Given this list of marker genes PTPN1 (NCBI Gene Id 5770), POP1, CSDE1, ACSL1, RAD23B, UCK2, RPS6KB1, FXR1, DNMT3B, FAM83G, CCT3, PAPOLA, TPST2, KTN1, TPM3, RAB14, NOL11, NUP62, CELF1, AAMP (angio associated migratory cell protein), DYNC1LI1, MIR4435-2HG (MIR4435-2 host gene), FUBP1, MAGEA3, BCCIP, DNAJC7, ABHD4, TCP1, CCT5, KIF3B, GCLM, PRDX1, SMCR8, EIF4H, EIF2B3, AHCYL2, HNRNPR, ATP6V1C2, NOP16, STAM, ACBD3, SEC24D, TRIB1, MRPS22, GAPDH, AHSA1, MACO1, NIP7, SCPEP1, PITHD1, HNRNPH1, KCTD5, DNAJC21, PLRG1, MRPL19, UBQLN1, CRELD2, MTDH, ZDHHC18, ABRAXAS2, BNIP3, PTPN11, SEL1L3, SLTM, HSPH1, PSMD4, TNFRSF10B (TNF receptor superfamily member 10b), EIF4G2, B4GALT5, YME1L1, DNAJC10, LIMK1, PLS3 (plastin 3), MAP1A, PRPF31, KIF5B, DNAJC6, CDC37 (NCBI Gene Id 11140), GATAD2A, SF3A3, PRPF4, FAT2, SLC66A1, CYTOR, PKM, ECE1, MANF, BAG2 (BAG cochaperone 2), KCMF1, WDR77, SLC7A5, CTSL, HSALR1, EIF4E, ISY1, TFG, STIP1, TAF5L, SSB, FXYD5, PSAP, GNPDA2, SMU1, RTN4, SNRK, HYOU1, FTL, DDX10, CCDC43, RABEP1 (NCBI Gene Id 9135), PHAX, FBXO28, SLC2A1, TTI2, AKR1B1, GTF2F1, KIDINS220, ME1, MPZL1, NAMPT, ANP32E, PRDX6, SUPV3L1, INTS13, BLMH, MAP7D1, SART1, HSPA8, TBC1D30, CYREN, PPP2CB, GLYR1, CTR9, SPART, TMTC3, SEC24C, USP14, SP140, FGFR1, GRB2, SURF4, KANSL3, CCDC47 (coiled-coil domain containing 47), SH3BP5L, UBE2D1, YRDC, SLC25A24, GTF3C3, CBFB, YWHAG, PSMD6, FAM168B, MPHOSPH10, NOLC1, NRIP3, LRRFIP2, UGDH, STX12, NGRN, GSTP1, IWS1, RYR3, KARS1, ADNP2 (NCBI Gene Id 22850), MBD1, ATP10D, TNPO3, SET, HNRNPK, SPAG9, B4GALNT1, KIAA1191, FAF2, SENP2, WDR26, CLIP1, NSUN2, DNAJC2, SH3BGRL2, STX18, DYNLL2, HMOX1, NDRG1, PPP2CA, ABCE1, GRPEL1, CCT6A, BPNT2, JAK1, XPOT, ABCD1, CNNM4 (cyclin and CBS domain divalent metal cation transport mediator 4), EXOC7, PJA1, CTTN, CA12, SNW1, MAPK6, TALDO1, TAF8, TP53BP2, SLC6A6, CDV3, PES1, BAG3, PAFAH1B1, DNAJC11, GABPB1, DLAT, MARK3, FAM98A, PPP2R5E, KCNA2, FTH1, ZDHHC9, SERPINE2, ALDH1B1, SDCBP, SLC39A6, PSMC3, HSPD1, COPS8, MAP2K1, SCFD1, TXNDC5, PRMT5, RBM6, BLTP2, EIF3J, MTHFD2, SYNCRIP, JMJD6, PIK3CD, ASAP2, SLC4A1AP, MGST1, DDX21, MRFAP1, NUP43, EDEM3 (ER degradation enhancing alpha-mannosidase like protein 3), RNF6 (NCBI Gene Id 6049), CLINT1, CALU, HSPA5, CUL1, TRMT6, GCC1, HSPA4, SEC61A1, NQO2, LDHB, SLC25A51, CMAS, PLEKHO2, ALAS1, PFKFB3, SOAT1, CHCHD3, MAP4K4, MCL1, C1orf198, ZC3H11A, CDK12, ANAPC1, RRP1, ACTR8, SRSF1, SLC7A11, CACYBP, POLR2B, PDIA6, SH3KBP1, IK, C9orf78, FBXW11, CHPF2, BRIX1, PGRMC1, BCL2L13, TMED10, CHST1, RPAP3, PPIF (peptidylprolyl isomerase F), TMEM168, TYRO3, KEAP1, TIMM17A, SEC23A, RPN2, ZNF746 (NCBI Gene Id 155061), WDR46, GNAI3, DDHD1, EXOSC3, ELMO1, PCYT1A, SLC1A5, NUDC, UBE2V1, RIOK2 (NCBI Gene Id 55781), MCUR1, NEK4, PRNP, CCT7 (chaperonin containing TCP1 subunit 7), MLEC, RTCA, TAOK3, SEC13, AAR2, MFN2, VEZT, SBDS, SRPK1, VPS54, UAP1, TBK1, CANX, YARS1, PPID, TMED5, VPS41, CUL4A, WDR36, TAF2, PRKCI, SBNO1, IST1, RARS1, DHX32, MAPRE1, PDAP1, FKBP14, LRRC59, UNKL, GPAT4, RAB1A, TM9SF3, ALDOA, CLCC1, ACAT2, TUBB3, ESF1, AKR1B10, XRCC6, GPX3, PELO, SAMD4B, ATMIN, ATP8B2 (NCBI Gene Id 57198), HARS1, EIF2S2, GAN, AKR1C3, CCT2 (chaperonin containing TCP1 subunit 2), SLC39A14, HNRNPA1, ARCN1, GNPNAT1, DNAJB11, TSR1, NFRKB, SCARB2, OSBPL11 (oxysterol binding protein like 11), HSPA9, CERK, PWWP2B, KIAA0930, ENTPD4, PSMB5, FXR2, DNAJA1, SLC16A1, RIOK1, E2F6, RCN1, AFG3L2, PPFIA1, GAPVD1, LIPH, PRECSIT, ALDH2, SFXN5, GFPT1, WDR3, LYAR, LMAN1, NACA, FYTTD1, BLOC1S5-TXNDC5 (NCBI Gene Id 100526836), ILRUN, MAP4K5, SYAP1, TMEM33, HTRA3, DKC1, PDIA3, FBXO30, TMBIM6, CLNS1A, RAB35, ITSN2, IMPDH1, RBM19, MRGBP, MAP4, PPP6R3, SMG5, NCKAP1, EIF2B1, AREL1, UBE2L3, CCT8, NARS1, ELAC2, EIF3H, SSR1, GTPBP4, DDX1, SMS, TTC27, here is a description of the gene set: species: Homo sapiens from publication Ibrahim L, Mesgarzadeh J, Xu I, Powers ET, Wiseman RL, Bollong MJ (PMID 33096892) The NRF transcription factors NRF1, NRF2, and NRF3, are a subset of Cap'n'collar transcriptional regulators which modulate the expression of genes harboring antioxidant-response element (ARE) sequences within their genomic loci. Despite the emerging physiological importance of NRF family members, the repertoire of their genetic targets remains incompletely defined. Here we use RNA-sequencing-based transcriptional profiling and quantitative proteomics to delineate the overlapping and differential genetic programs effected by the three NRF transcription factors. Comparing our data to recent profiling analyses, we create consensus target gene sets regulated by NRF1, NRF2, and NRF3, genetic programs which we determine to be differentially regulated in human tissues. Together, our data provide a quantitative assessment of how NRF family members sculpt proteomes and transcriptomes, essential information for future studies evaluating the role of NRF factors in normal physiology and disease. Human Gene Set: IBRAHIM_NRF1_UP Genes up-regulated in HEK293T cells overexpressing FLAG-NRF1